Given this list of marker genes MATN3, B3GALT6, PAPSS2, DDRGK1, DDR2, TONSL, ACAN, MMP13, COL2A1, NANS, RSPRY1, EXOC6B, KIF22, BGN, IARS2, AIFM1, DYM, here is a description of the gene set: studied in species Homo sapiens Spondyloepimetaphyseal dysplasia Human Gene Set: HP_SPONDYLOEPIMETAPHYSEAL_DYSPLASIA